The following is a description of a gene set: Mouse Gene Set: GOCC_DNA_DEPENDENT_PROTEIN_KINASE_DNA_LIGASE_4_COMPLEX species: Mus musculus A large protein complex which is involved in the repair of DNA double-strand breaks and, in mammals, V(D)J recombination events. It consists of the DNA-dependent protein kinase catalytic subunit (DNA-PKcs), the DNA end-binding heterodimer Ku, the nuclear phosphoprotein XRCC4 or a homolog thereof, and DNA ligase IV., and this is the list of marker genes: Nhej1, Lig4, Xrcc4, Xrcc5, Xrcc6, Prkdc